Given this list of marker genes DENND4A, C1orf21, ABCC3, PRKCI, CEP41, NUDT13, ALG6 (NCBI Gene Id 94752), SIX1, AGBL4, SYT1, PTPRT, P4HA1 (NCBI Gene Id 5033), ARHGEF33, RNF168, RAB3B, SPRY2, HNRNPDL, TINF2, CNR2, POLE4, KCTD20, SPATA6L, SMIM13, RIC3, CERS6, FLT1, NPTN, ANGPT2, SNX20, VDAC2, TMEM221, CAMKV, PRR5L, ATRNL1, ONECUT2, LEMD3, TTL, RSPH4A, KCTD3, MSL2, GFI1 (growth factor independent 1 transcriptional repressor), KPNA5, HSDL2, RRP15, AMOT, RUNDC3B, FAM168A, MON1B, PEX11G, NETO1, PCYT1A, RNMT, HM13, OLIG2, HIF1AN, CUL5, BECN1, RABEP1, ADAM23, PPT1, APPBP2, ZNRF3, STK3, VWC2, PIK3R3, SLC25A25, CCAR1, SEPTIN4, SMARCAD1, SLFN13, MICU1, DPY19L3, CLIP4, IFIT5, NOTCH2NLA, CREB1, DCX, here is a description of the gene set: from publication Chen Y, Wang X (PMID 31504780) Human Gene Set: MIR6072 Genes predicted to be targets of miRBase v22 microRNA hsa-miR-6072 in miRDB v6.0 with MirTarget v4 prediction scores > 80 (high confidence targets). studied in species Homo sapiens